The following is a description of a gene set: studied in species Mus musculus from publication Chen Y, Wang X (PMID 31504780) Mouse Gene Set: MIR_451A Genes predicted to be targets of miRBase v22 microRNA mmu_miR_451a in miRDB v6.0 with MirTarget v4 prediction scores > 80 (high confidence targets)., and this is the list of marker genes: Osr1, Macroh2a1, Cdkn2d, H2bc6, Zfp142, Casq1, Kifc5b, Cep55, Vapa, Ints10